Given this list of marker genes HMOX1, DUSP1, JUN, HSPB1, CRYAB, HSPA1A, here is a description of the gene set: Selected genes up-regulated in Rat1Ras cells (fibroblasts) which were transformed by expression of an oncogenic activated form of HRAS compared to the parental Rat1 cells. Heat shock proteins (Hsps) are overexpressed in many tumors, but are downregulated in some tumors. To check for a direct effect of Ha-Ras(val12) on HSP70 transcription, we transiently expressed the oncoprotein in Rat1 fibroblasts and monitored its effect on HSP70b promoter-driven reporter gene. We show that expression of Ha-Ras(val12) induced this promoter. Promoter analysis via systematic deletions and point mutations revealed that Ha-Ras(val12) induces HSP70b transcription via heat shock elements (HSEs). Also, Ha-Ras(val12) induction of HSE-mediated transcription was dramatically reduced in HSF1-/- cells. Yet, residual effect of Ha-Ras(val12) that was still measured in HSF1-/- cells suggests that some of the Ha-Ras(val12) effect is Hsf1-independent. When HSF1-/- cells, stably expressing Ha-Ras(val12), were grown on soft agar only small colonies were formed suggesting a role for heat shock factor 1 (Hsf1) in Ha-Ras(val12)-mediated transformation. Although Ha-ras(Val12) seems to be an inducer of HSP70's expression, we found that in Ha-ras(Val12-)transformed fibroblasts expression of this gene is suppressed. This suppression is correlated with higher sensitivity of Ha-ras(val12)-transformed cells to heat shock. We suggest that Ha-ras(Val12) is involved in Hsf1 activation, thereby inducing the cellular protective response. Cells that repress this response are perhaps those that acquire the capability to further proliferate and become transformed clones. Human Gene Set: STANHILL_HRAS_TRANSFROMATION_UP species: Rattus norvegicus from publication Stanhill A, Levin V, Hendel A, Shachar I, Kazanov D, Arber N, Kaminski N, Engelberg D (PMID 16278678)